Given this list of marker genes TBL1XR1, AFF2, ARX, DIS3L2, RECQL4, B3GALT6, TRPS1, SLC35C1, here is a description of the gene set: Human Gene Set: HP_LONG_UPPER_LIP Long upper lip Increased width of the upper lip. studied in species Homo sapiens